The following is a description of a gene set: species: Homo sapiens BACKGROUND: The aggressiveness of metastatic neuroblastomas that lack MYCN gene amplification varies with age--they are least aggressive when diagnosed in patients younger than 12 months and most aggressive when diagnosed in patients older than 24 months. However, age at diagnosis is not always associated with patient survival. We examined whether molecular classification of metastatic neuroblastomas without MYCN gene amplification at diagnosis using gene expression profiling could improve the prediction of risk of disease progression. METHODS: We used Affymetrix microarrays to determine the gene expression profiles of 102 untreated primary neuroblastomas without MYCN gene amplification obtained from children whose ages at diagnosis ranged from 0.1 to 151 months. A supervised method using diagonal linear discriminant analysis was devised to build a multigene model for predicting risk of disease progression. The accuracy of the model was evaluated using nested cross-validations, permutation analyses, and gene expression data from 15 additional tumors obtained at disease progression. RESULTS: An expression profile model using genes defined a tumor signature that distinguished two groups of patients from among those older than 12 months at diagnosis and clinically classified as having high-risk disease, those with a progression-free survival (PFS) rate of 16% (95% confidence interval = 8% to 28%), and those with a PFS rate of 79% (95% CI = 57% to 91%) (P<.01). These tumor signatures also identified two groups of patients with PFS of 15% (95% CI = 7% to 27%) and 69% (95% CI = 40% to 86%) (P<.01) from among patients who were older than 18 months at diagnosis. The gene expression signature of untreated molecular high-risk tumors was also present in progressively growing tumors. CONCLUSION: Gene expression signatures of tumors obtained at diagnosis from patients with clinically indistinguishable high-risk, metastatic neuroblastomas identify subgroups with different outcomes. Accurate identification of these subgroups with gene expression profiles may facilitate development, implementation, and analysis of clinical trials aimed at improving outcome. Human Gene Set: ASGHARZADEH_NEUROBLASTOMA_POOR_SURVIVAL_DN from publication Asgharzadeh S, Pique-Regi R, Sposto R, Wang H, Yang Y, Shimada H, Matthay K, Buckley J, Ortega A, Seeger RC (PMID 16954472) Down-regulated genes associated with poor survival prognosis of patients with metastatic neuroblastoma that lack MYCN amplification., and this is the list of marker genes: BTBD3, PLPPR3, GATAD2B, ZNF91, SCN3B, HIVEP3, ZNF710, CACNA1G, PGM2L1, ST7, FUBP1, NTRK1, ADCY1, GFRA3, DDHD2, ERCC6L2-AS1, GNAI1, FAXC, CNR1, SCN3A, APBA2, SOX4, SDK1, WDR33, FOXP1, THAP2, TMOD2, TADA2A, SPTBN4, SNHG29, ST8SIA2, H2AZ2, HRK, GPR85, CHD3, CILK1, C1orf35, CENPBD1P, SMARCE1, CAMTA1, HOXC6, HAP1, USP8